The following is a description of a gene set: Mouse Gene Set: GOBP_NEGATIVE_REGULATION_OF_EPITHELIAL_CELL_PROLIFERATION species: Mus musculus Any process that stops, prevents or reduces the rate or extent of epithelial cell proliferation., and this is the list of marker genes: Intu, Phox2b, Stat1 (signal transducer and activator of transcription 1), Pten, Ift122, Sfrp1 (NCBI Gene Id 72362), Sav1, Dlg1, Lims2, Etv4, Gja1, Tnmd, Wfdc1, Acvrl1, Ceacam2, Men1, Krit1, Rgcc, Zfas1, Marveld3, Tinf2, B4galt1, Apoh, Ptch1, Smo, Wdr77, Apoe (NCBI Gene Id 11816), Nfatc1, Bmp4, Nr2f2, Gpc3, Maged1, Ar, Cdkn1c, Cdh1, Phb2, Sox2, Tsc2, Sox9, Tgfbr1, Ift57, Klf9, Hpn, Nupr1, Sparc, Cdc73, Drd2, Ovol1, Xdh, Eppk1, Ngfr, Eng, Wdr13, Ptprk, Tgfb2, Ift88, Isl1, Trim24, Gata3, Cxcr3, Muc16, Atoh8, Nkx3-1, Hsf1, A4gnt (alpha-1,4-N-acetylglucosaminyltransferase), Slurp1, Kdf1, Nlrc3, Atf2, Fgfr3, Ptprm, Rida, Stk3, Ift80, Dsc1, Atp5f1a, Ift172, Efnb2, Dab2ip, Wnt10b, Ift52, Prl (prolactin), Vdr, Notch1, Stk4, Ift74, Lrp6, Tgfb3, Dusp10, Zeb1, Cav1, Col4a3, Pdcd10, Pla2g2a, Il12b, Ceacam1, Gdf5, Vash1 (NCBI Gene Id 263410), Alox5, Nf1, Aqp11, Nfib (NCBI Gene Id 77183), Esr2, Lims1, Flcn, Npm1, Sulf1, Dab2, Synj2bp, Irf6, Cpb2, Serpinf1, Cdk6, Krt4, Ghrl (NCBI Gene Id 80454), Pparg, Stk11, Dll4, Ppard, Pex2, Tgfb1, Cnmd, Rb1, Pax6, Rgn, Eaf2, Thbs1, Sfn, Nkx2-9, Dlk1, Cask, Sfrp2, Cdkn1b, Ctsl, Ager, B2m, Runx3, Aimp1, Snai2, Apc, Gata6, Fgfr2, Flt1, Ptn, Tmigd1, Wnt5a, Rian, Pdx1, Gas1, Cdkn2a, Ccl12, Tgfbr3, Mcc, Gdf2, Robo1, Rap1gap, Brca2, Cav2, Med1, S2bpcox16, Atp5if1, Il12a, Mtss1, Mef2c, Tnf, Mmrn2, Gkn3, Cd109, Suz12, Nppb, Celf1, Cdkn2b